Given this list of marker genes KRT10, KLK7, TP63, ITGB4, GJB3, LGALS7, KRT1, FLG, EGF, KPRP, NUMB, KRTDAP, TFRC, DMKN, FABP5, CASP14, IVL, ABCG2, CSPG4, LORICRIN, KRT5, LGALS7B, KRT19, SBSN, SPRR2A, YAP1 (NCBI Gene Id 10413), LRIG1, HOPX, KRT15, AQP3, SPINK5, CALML5, ITGB1, KLK5, KRT78, KRT24, KRT14, PRSS3, DLL1, ITGA6 (NCBI Gene Id 3655), here is a description of the gene set: Differentiation of Keratinocytes in Interfollicular Epidermis in Mammalian Skin studied in species Homo sapiens Human Gene Set: REACTOME_DIFFERENTIATION_OF_KERATINOCYTES_IN_INTERFOLLICULAR_EPIDERMIS_IN_MAMMALIAN_SKIN